Given this list of marker genes PHLDA2, NQO1, IGF2BP3, SP100, CST1, CST2, CCDC28A, HSPA1A, ARPC2, MMP1, PTPRN2, MMP9, MRPL9, ARHGDIB, CST4, PVR, here is a description of the gene set: studied in species Homo sapiens PKCalpha and Ets1 are both associated with breast cancer progression. Our previous studies suggested that these proteins are likely to functionally interact with one another. Here, we show that attenuation of endogenous PKCalpha expression (siPalpha) by RNA interference leads to reduced Ets1 protein expression in a variety of cancer cells. Pulse-chase experiments and treatment with proteasome inhibitor MG-132 revealed that siPalpha interferes with both Ets1 protein synthesis and stability. The effect of siPalpha on Ets1 expression could be partially prevented by KN-93, suggesting that calcium/calmodulin-dependent kinase II (CaMKII), a modulator of Ets1 activity, may play a role in PKCalpha-dependent Ets1 regulation. In contrast, Ets1-regulating kinases ERK1/2 were not found to be involved in this process. To assess the importance of the PKCalpha/Ets1 interaction, we compared the biological responses of MDA-MB-231 cells to PKCalpha- and Ets1-specific siRNAs (siE1). While only siPalpha induced changes in cellular morphology and anchorage-independent growth, both siRNAs similarly affected cellular responses to the antitumor drug mithramycin A and to UV light. Microarray analyses further showed that the expression of a certain set of genes was equally affected by siPalpha and siE1. The data suggest that Ets1 serves as an effector for PKCalpha to fulfil certain functions in cancer cells. Human Gene Set: VETTER_TARGETS_OF_PRKCA_AND_ETS1_DN Genes down-regulated in MDA-MB-231 cells (breast cancer) after knockdown of PRKCA and ETS1 by RNAi. from publication Vetter M, Blumenthal SG, Lindemann RK, Manns J, Wesselborg S, Thomssen C, Dittmer J (PMID 15531915)